The following is a description of a gene set: Warburg effect modulated by deubiquitinating enzymes and their substrates Human Gene Set: WP_WARBURG_EFFECT_MODULATED_BY_DEUBIQUITINATING_ENZYMES_AND_THEIR_SUBSTRATES species: Homo sapiens, and this is the list of marker genes: VEGFA, OTUD6B, USP28, HK2, OTUD7B, FOXO1, G6PC1 (glucose-6-phosphatase catalytic subunit 1), OTUB2, USP7, AKT1, PIK3CA, MYC, KDR, PGK1, FBP1, LDHA, HIF1A, PGAM1 (NCBI Gene Id 95038), MTOR, SLC2A1, VHL, USP37, U2AF2, SIRT7, USP19, USP44